Given this list of marker genes PYGB, HSD3B7, SLC25A26, BEX3, TBC1D23, CDK5RAP3, ORMDL2, ZNF394, NDUFS3, TLR4, RECQL (NCBI Gene Id 5965), FAM216A, PLD3, CTNNBIP1, IRF2BP1, TULP3, RENBP, LIN37, TMEM126A, ZNF106, TNPO1, JKAMP, RMC1, RABEPK, METTL8, PCMTD2, CEP57L1, MRPL41, GALNS, RARS2, TOMM40L, SERINC3, SARAF, ACOT13, SIL1, FUNDC1, S1PR5, ZFP36L2, UCKL1, MAP4K1, ASPH, SLC46A3, BOLA1, SPTBN1, PSEN1, SNTB2, SNAP47, PRDX2 (peroxiredoxin 2), RPS6KA3, ADISSP, RETREG1, NET1, DYNLT1, DDRGK1, SLC41A1, TXNRD2, GALM, MTERF4, ATF6, ULK2, COMT, MTMR10, RNF167, AKR1E2, PER1, CIPC, BRCC3, PXMP2 (NCBI Gene Id 5827), GRB2, C15orf39, DALRD3, ZFPM1, CAMK4, NAPA, STEAP3, ATP6V1D, SLC35B4, NCKAP1L, GPCPD1, FBXL14, BABAM1, POLR2A, ANXA5, D2HGDH (D-2-hydroxyglutarate dehydrogenase), ADSS2, CUX1, DHX8, TAFAZZIN, ITPR3, MYOF, NEK9, AP2A1, CBFA2T2, SNX21, WDFY1, DHFR, JUN, EBAG9, OLFML3, CTSA, CTNS, R3HCC1, HSPA4L, TMEM19, ATMIN, PRKAG2, GGA2, CDADC1, DLAT, UBR3, R3HDM1, INVS, IFT70B, AQR, RASSF2, SNX15, TNRC6B, VPS50 (NCBI Gene Id 79604), LTO1, KIFC3, SASH3, HDAC7, SEPTIN8, JMJD8, DCTN5, SDHA, DGKZ, ETFDH, GNPDA1, FAM53A, NDUFAF1, DHRS3, ATP6V1G2, MED30, C5orf34, ASH2L, CYTH1, CDK4, TUFM, PCYT1A, UGP2, RPRM, IDH3B, DNAJC14, STAMBPL1, OST4, IVNS1ABP, TYW1, MNT, CDO1, MBP, SLAIN2, RELL1, NUDC, SCAMP5, SIAE, AASS, SLC66A1, GAK, TMEM184C, DIO2, DHCR7, ANXA4, PGM1, WWOX, TPGS1, C7orf25 (NCBI Gene Id 79020), LATS2, KGD4, KLHL22, RSPH9, MAPRE2, ZNF395, SPECC1, VPS25, TMEM33, DDX41, FAHD1, RPA1, ADAM15, AP1G2, LIPA, ZDHHC14, ANXA9 (NCBI Gene Id 8416, annexin A9), TMEM80, RAB31, ACOX3, HABP4, RBBP9, NTPCR, MEF2C, LTN1, FBXW4, KIAA0930, CIAO1, SLC4A4, ZNF282, MXI1, TRPV2, PHAF1, here is a description of the gene set: Genes up-regulated in macrophages: untreated versus 12h after M. bovis BCG infection. Human Gene Set: GSE22935_UNSTIM_VS_12H_MBOVIS_BCG_STIM_MACROPHAGE_UP from publication Qualls JE, Neale G, Smith AM, Koo MS, DeFreitas AA, Zhang H, Kaplan G, Watowich SS, Murray PJ (PMID 20716764) species: Homo sapiens Nitric oxide (NO) produced by macrophages (MØs) is toxic to both host tissues and invading pathogens and its regulation is therefore essential to suppress host cytotoxicity. MØ arginase 1 (Arg1) inhibits NO production by competing with NO synthases for arginine, the common substrate of NO synthases and arginases. Two signal transduction pathways control Arg1 expression in MØs. First, a MyD88-dependent pathway induces Arg1 in intracellular infections, while a second Stat6-dependent pathway is required for Arg1 expression in alternativelyactivated MØs. We found that mycobacteria-infected MØs produce soluble factors that induce Arg1 in an autocrine-paracrine manner via Stat3. We identify these factors as IL-6, IL-10 and GCSF. We further establish that Arg1 expression is controlled by the MyD88-dependent production of IL-6, IL-10 and G-CSF rather than cell intrinsic MyD88 signaling to Arg1. Our data reveal the MyD88-dependent pathway of Arg1induction following BCG infection requires Stat3 activation and may result in the development of an immunosuppressive niche in granulomas due to the induced Arg1 production in surrounding uninfected MØs